The following is a description of a gene set: Reactome Pathway: Removal of aminoterminal propeptides from gamma-carboxylated proteins part of: Gamma-carboxylation, transport, and amino-terminal cleavage of proteins Furin is an endopeptidase localized to the Golgi membrane that cleaves many proteins on the carboxyterminal side of the sequence motif Arg--(Lys or Arg)-Arg. In the case of gamma-carboxylated proteins, if this cleavage does not occur, the proteins are still secreted but do not function properly. The aminoterminal fragments, "propeptides", generated in this reaction have no known function; the carboxylated, cleaved proteins are delivered to the cell membrane or secreted from the cell. studied in species Homo sapiens, and this is the list of marker genes: PROS1, PROC (NCBI Gene Id 5624), F10, F9, PROZ, GAS6, F7, BGLAP, FURIN, F2